Given this list of marker genes CELA1, CTSL, CST3, MIR181B1, MMP12, here is a description of the gene set: species: Homo sapiens Human Gene Set: GOBP_ELASTIN_CATABOLIC_PROCESS The chemical reactions and pathways resulting in the breakdown of elastin. Elastin is a glycoprotein which is randomly coiled and crosslinked to form elastic fibers that are found in connective tissue.